Given this list of marker genes CD72, SMAGP, TACC2, ARHGEF12 (Rho guanine nucleotide exchange factor 12), CD99L2, PDE4DIP, H2BC13, PKP4, RAB2B, DAB2IP, CD28, MFSD6, TMEM126B, GPC1, TENM4, LRRC8C, HEATR5A, PPARD, AHSA1, EPN2, OXCT1, IER5L, KIF26B, ESD, RBP4, PEDS1, NES, BMP2, SLC12A5, GOLGB1, LANCL2 (NCBI Gene Id 95548), P2RY1, NDST1, MTSS1 (MTSS I-BAR domain containing 1), PRKG1, CD40, DNAJB7, CTSA, DNAAF9, FLOT1, PPARG, TEC, SESTD1, SFPQ, APBB2, IL6ST, TIMM23, NINJ1, CXCL16, GSDME, PPP1R14D, DEPDC5, PAFAH2, AQP9, TSPAN7, AHNAK (NCBI Gene Id 79026), SFMBT1, DLG3, FN1 (NCBI Gene Id 2335), IFT22, PLAU, SRPX2, CAPG, PTPRA, TMOD1, EEIG1, DOCK2, BLMH, DEGS1, ARHGAP6 (Rho GTPase activating protein 6), GALNT6, PPIC (NCBI Gene Id 5480), ERP29, CLSTN1, SHISA2, SEPTIN8, HEXB, PRDX4, TRIM2, MDH2, DNAL1, DAG1, ZDHHC18, GOT1, GPR65 (G protein-coupled receptor 65), FRMD6, SPRYD7, S1PR2, HIGD1C, CLEC4D, EMP2, RNF128, SACM1L (SAC1 like phosphatidylinositide phosphatase), CNRIP1, MCCC1, EPS15, ITGAX, ABCA1, ANTXR2, PTPRS, TRIP10, GPR176, PRNP, KLHL13, TSPAN3, GAS6, ENSA, SLC25A13, ARID5A, CASP2, MED11, CRELD1, TCEAL8, NPL, SLC26A11, LONRF3, IGF2BP2, AFP, LY86, CLCN5, ALCAM, KIF3A, NLK, BAMBI (NCBI Gene Id 25805), CD5L, PRKCB, AOPEP, SRGN, ACP7, HBEGF (heparin binding EGF like growth factor), MCOLN2, PSAP, ADAM9, HOMER1, BLCAP, PTCD2, ARAP2, DMWD, PIK3CB, LPP, UAP1L1, RAB24, CHST11, TCEAL7, TARDBP, CHST7, MAMDC2, ETS1, RAB11FIP3, CDC42SE2, GRN, MARVELD3, TES, RNF150, VWF, SNRPA1, ADAM8, ATP1A3, ITGA6, DHPS, BEX3, TMEM120A, CBLB, RHOB, LAYN, MNT, PGAP6, NCOA5, TTC39C, STON2, CD81, IRF5, FAM110C, NRP1, MBTPS1, LMAN2L, DCXR, CDS2, MFGE8, CBL, PFN2, RAB6A, MAP1LC3A, TTC12, PTGS1, PRKD3, ST3GAL2, SPHK1, ATP13A1, TANC1, RASGRP2, TMEM68, GSTM1, EFR3B, RAB19, CD99, SLC36A2, PDP1, GASK1B, PPFIA1, here is a description of the gene set: Human Gene Set: GSE5589_LPS_VS_LPS_AND_IL6_STIM_IL6_KO_MACROPHAGE_45MIN_UP species: Homo sapiens Genes up-regulated in bone marrow-derived macrophages with IL6 knockout and 45 min of stimulation by: LPS versus IL6 and LPS. from publication El Kasmi KC, Holst J, Coffre M, Mielke L, de Pauw A, Lhocine N, Smith AM, Rutschman R, Kaushal D, Shen Y, Suda T, Donnelly RP, Myers MG Jr, Alexander W, Vignali DA, Watowich SS, Ernst M, Hilton DJ, Murray PJ (PMID 17114459) IL-10 or IL-6 stimulation of control 129xC57BL/6 murine bone marrow derived macrophages in the presence of LPS. We used microarrays to detail the global programme of gene expression changes in response to IL-6 or IL-10 stimulation in the presence of lipopolysaccharide. BMDMs were isolated from control, IL-6-/-, and IL-10-/- mice on a 129XBL/6 mixed background mice and differentiated in the presence of CSF-1 for 6-7 days. Cells were scraped and plated in 6 well plates at 2x10e6/well. Cells were washed with complete DMEM and rested for 1-2 hr before stimulation with combinations of IL-10 (10 ng/ml), IL-6 (2 ng/ml) or LPS (100 ng/ml) for 45 min or 180 mins. Complete biological replicates were performed.